Given this list of marker genes RARB, ATF2, FGFR3, ZMPSTE24, FOSL2, FGFR2, SMPD3, MMP13, COMP, COL27A1, MATN1, IFT80, EXT1, THBS3, TGFBR2, STC1, POR (NCBI Gene Id 96440), POC1A, RARG, CER1, MSX2, FBLN5, SOX9, EVC, NPPC, NPR2, TSKU (NCBI Gene Id 25987), ECM1, LEP, BNC2, RARA, DDR2, OSTN, LEPR, here is a description of the gene set: Human Gene Set: GOBP_BONE_GROWTH The increase in size or mass of a bone that contributes to the shaping of that bone. species: Homo sapiens